The following is a description of a gene set: Human Gene Set: HP_ABNORMAL_RENAL_PHYSIOLOGY species: Homo sapiens An abnormal functionality of the kidney. Abnormal renal physiology, and this is the list of marker genes: TRMT5, BRCA2, AP1S3, COL4A5, POU6F2, PHKB, SMC1A, SCNN1A, NDUFAF8 (NCBI Gene Id 284184), APC2, NUBPL, FN1, REN, HLA-DPB1, ADA, MYH11, VPS33A, DNASE1, IL23R, SLC17A5, BICC1, TBC1D8B, ABCC6, UMPS, HPS1, ETFDH, RRAGD (NCBI Gene Id 58528), DNMT3A, CR2, SLC22A12, NUP85, SMC3, SDHAF2, KLF11, IL36RN, NDUFB3, PBX1, TRIP13, HMBS, TCF4, HPRT1, EHHADH, TTC8, OCRL, OCLN, NUP160, CFHR3, HGD, GLIS2, OSGEP, CLDN10, APOE, TBX18, SALL1, CFAP418, SDCCAG8, FCGR2A (NCBI Gene Id 90764), TNFAIP3 (TNF alpha induced protein 3), ACTN4, BBIP1, IFNGR1 (interferon gamma receptor 1), CTNS, NDUFA6, OFD1, SEMA4D, RAG2, SLC4A4, COL4A6, UQCC2, CISD2, IRF5, COA8, NPHS1, NCF1 (NCBI Gene Id 653844), GSN, DACT1, GP1BA, AQP2, ATP7B, HSD11B2, AMN, ALDH4A1, RPGRIP1L, MYH9, SCAPER, ARL6, FBXL4, TRIM28, FGA, MYO1E, LCAT, MAX, NUP205, SCNN1B, MPV17 (mitochondrial inner membrane protein MPV17, NCBI Gene Id 4358), ERCC4, IFT27, NUP133, MYD88, SLC5A2, BLK, TGM1, NDUFS8, KCTD1, TBX1, FAM20A, PXK, CPT1A, FH, PAX4, NEK8, NDUFS7, SIX5, KIRREL1, KMT2D, FANCA, RNU7-1, SPTBN1, IL17F, GTF2IRD1, STOX1, ATP1A1, IL17RC, FUZ, AGT, LTBP1, EBF3, ANKS6 (ankyrin repeat and sterile alpha motif domain containing 6), MT-CO3, PML, B2M, UBE2T, RET, CD109, ELP1, KLRC4, FANCB, ETFA, ZNF592, SPRY2, ALG9, NDUFAF6, KIF1B, ITGA2, GP1BB, CD2AP, SDHB, IFT56, FIG4, APRT, BRCA1, P4HA2, BBS10, MYO5B (NCBI Gene Id 4645), NADK2, CRB2, PKD1, NDUFB11, MT-ND4, IGHG1, MCFD2, RMRP, IFIH1, CEP290, RMND1, SLC2A9, APOA1, VANGL1, MT-ND6, CLEC7A, MME, ROBO1, PLVAP, IL6, ARHGDIA, XDH, DSTYK, SON, TTR, MT-TL1, CLIP2, DNAJB11, TMEM138, ELN, NSD1, C3, TRAF3IP1, TLR7, ALDH18A1, CC2D2A, TMEM231, VAMP7 (vesicle associated membrane protein 7), AVPR2, CYP24A1, CASP10, CHD7, NR5A1, MT-ND1, APPL1, PDSS2, LIMK1, MAGED2, STS, MMUT, LAMB2, NTRK1, SRY, GPR35, AMMECR1, PRTN3, GATA3, INVS, SLX4, C4A, MTRR, WDR19, JAZF1, CAV1, F2, RFWD3, SARS2, CFB, SCARB2, MYCN, ALG5, ZFPM2, JAK1, G6PC1, NLRP3, EYA1, TPRKB, PAX2, ACE, IFT74, SOX9, NDUFA1, LAGE3, ABCA12, AGGF1, CD46, RASA1, FLT1, TRIM8, OBSCN, SLC25A20, NPHS2, TRIM32, BBS4, DYNC2I1, XYLT1, F5, SHPK, SLC7A7, TCN2, MYOCD, ATP6V0A4, WAS, MOCOS, DLST, FOXP3, LRP2, UBE2L3, HPSE2, CHRNA3, FANCE, DHDDS, XIAP, CLCN5, GON7, HLA-DRB1, PRF1 (NCBI Gene Id 5551), ITGAM (NCBI Gene Id 3684), COQ2, KIAA0753, BBS5, SDR9C7, HMOX1, IFT43, SPP1, IL12A-AS1, SAT1 (spermidine/spermine N1-acetyltransferase 1), NDUFV1, HLA-B (NCBI Gene Id 730410), PFKM, FKBP6, IFNG, DCDC2, DCLRE1C, FANCM, WFS1, FANCF, NDUFAF5, ITGA3, FXYD2, IRAK1, TSC1, KARS1, KCNJ5, SDHC, SLC26A1, KCNJ11, YWHAE, EHMT1, ITGB3, TMEM216, MARS1, NIPAL4, STAT5B (NCBI Gene Id 6777), SLC41A1, PEX7, MIF, DNAJC30, CNNM2, FANCI, IQCB1, PKHD1, LPIN2, SLC34A3, IL10, NOTCH2, BBS1, COQ8B, ETFB, NOS1AP, CEP19, ERAP1, TAF6, CCN2, NUMA1, F8, ASL (NCBI Gene Id 435), ALDOB, MT-ND3, FOXI1, LACC1, SLC5A1, COL7A1, MAP3K1, NDUFA11, PHEX (NCBI Gene Id 5251), IL2RG, IL17RA, PIGA, TBL1XR1, LDHA, CCR1, VPS33B, WDR35, SMARCAL1, GALNT3, BNC2, MT-TS2, ZNFX1, MT-TQ, NOD2, NUP107, NDUFB10, TLR4, FBLN5, FAS, SLC3A1, LMX1B, C4B, UBAC2, KCNJ1, GAPVD1, ALMS1, PRPS1, KCNJ10, ACBD6, DYNC2LI1, NEUROD1, ABCC8, NDUFAF1, CFHR5, MT-TH, LHX1, MT-ND5, YRDC, METTL27, BUD23, CEP164, MPI, SERPINA1, PLCE1, PNPLA6, MED12, CHST14, MT-ND2, NPHP4, STX3, FCGR2B, SDHA, MAPKBP1, NDUFS1 (NADH:ubiquinone oxidoreductase core subunit S1), CPT2, MT-CO1, WIPF1, HOGA1 (NCBI Gene Id 112817), IFT122, PRKAR1A, CFHR1, RARA, CHRM3, CDK4, LMNB2, GTF2IRD2, WWOX, TRPC6, HNF4A, COG1, IVD, DMP1, TMEM165, MLXIPL, PALB2, ERCC8, PRDX1, MST1, NDUFS6 (NADH:ubiquinone oxidoreductase subunit S6), TMEM67 (transmembrane protein 67), CSPP1, ENPP1, ACP5, PIK3CA, DGKE, FASLG (Fas ligand), CA2, REST, STAT3, INF2, ACSL4, JAG1, CLCNKA, ETS1, RAD51, GATM, STX11, PRKCD, MECP2, TMEM126B, RFC2, SNAP29, CEL, HNF1A, BRD4, PMM2, GATA4, LRIG2, COL4A4, IL12A, EIF2AK3, SIX1, NOP10, FOXRED1, CFH, KDM6A (lysine demethylase 6A), RAG1, YAP1, HNRNPK, MKS1, EPAS1, FAH, NDUFAF3, UNC13D, WDR73, GP9, TNIP1, PAFAH1B1, HIC1, CAD, NDUFS2, EMP2, COL3A1, JAK2, PHYH, TBL2, CCNQ, COQ6 (coenzyme Q6, monooxygenase), CYBC1 (cytochrome b-245 chaperone 1), SLC26A4, CD81, ZAP70 (NCBI Gene Id 7535), CLDN16, PYGM, STIM1, COL4A1, VIPAS39 (NCBI Gene Id 63894), PLG, AVIL, F9, AHI1, COPA, TNFSF4, CD151, CASR, CTLA4, INS, PHKG2, SLC4A1, NPHP1, NR0B1, SCLT1, NIPBL, PC, IL7R, VPS37D, PHKA2, BBS2, TREX1, GCK, WDR4, CALR, SLC25A11 (NCBI Gene Id 8402), MEFV, DHX37, SLC2A2, KANK2, SOX18, BBS12, KIAA0586, ITGB4, TIMMDC1, PKDCC, DPH1, BRIP1, LZTFL1, SLC12A3, ALDOA, FCGR3B, LIPN, ANKFY1, BTNL2, GTF2I, MDH2 (NCBI Gene Id 4191), MUC1, MT-TW (NCBI Gene Id 4578), IRF2BP2, MT-TT, SLC30A9, SLC37A4, CCND1, STX1A, MAD2L2, NABP1, PGM3, SLC35A2, NUP93, NDUFS3, SLC34A2, CHD4, HNF1B, LIG4, TTC21B, TBK1, CLPB, TSC2, ADA2, KIAA0319L, EFEMP2, NF1, YY1AP1, STXBP2, ZNF699, INPP5E, F10, SURF1, GCM2, CACNA1S, NFS1, MKKS, SCNN1G, BCS1L, ATP6V1B1, COL4A3, STAT1, ITGA6, TAPBP, CEP120, EIF4H, LARS2, AP2S1, ANLN, DZIP1L, CUBN, PPOX, NEXMIF, GANAB, C1GALT1C1, PEX19, NDUFS4, TMEM270, HLA-DPA1, CCR6, KCNJ2, FCGR2C, SLC34A1, SOCS1, PDCD1, VAC14, GNAS, MAGI2, BCOR (NCBI Gene Id 57686), SLC7A9, ZMPSTE24, COL6A1, PGAM2, SAA1, RRM2B, RYR1, BBS9, DYNC2H1, NDUFAF2, HRAS, DYNC2I2, XRCC2, MEN1, PRODH, GBA1, RAD21, GCDH, BBS7, FAN1, CLDN19, LPIN1, SREBF1, NUP37, DIS3L2, CLCNKB, LYZ, XPNPEP3, CEP83, TMEM260 (transmembrane protein 260), BAZ1B, RAD51C, AGTR1, NDUFAF4, TRAF3IP2, SGPL1, CFI, PAX6 (NCBI Gene Id 5080), H19, GPC3, MT-TF, CDC73, HBB, ITPR3, FANCD2, BSND, NPHP3, ARPC5, APOL1, ASPRV1, ERCC6, COG6, DOCK11, VHL, SLC4A2, ZMYM3, ALOX12B, STAT4, SULT2B1 (NCBI Gene Id 6820), MMACHC (NCBI Gene Id 25974), MAFB, WDPCP, TAOK1, DNASE1L3, HOXA13, ZBTB16, MT-TN, DNASE2, SRCAP, PTPRO, ADAMTS13, FANCG, GLA, CYP4F22, CORIN, ZNF423, HMGA2, BANK1, SH2B1, IFT140, THBD, MMP1, IFT172, MT-CO2, SEC61A1, NDUFB9, KYNU, SERPINF2, ALG1, CPOX, FANCL, ALOXE3, IFT80, WT1, PTPN22, UMOD, FANCC, PUS3, NDUFV2, DKC1, SDHD, AGXT, SLC12A1, ITGA2B, LMAN1, C1QA, KL, STAT2, TMEM237, NPM1, GRHPR, C1QBP, DAAM2, FIP1L1, PGK1, CYB561, TMEM127, LAMA5, TP53RK, PKD2, PDX1, XYLT2, EPG5, IKZF1, ARHGAP24, POLRMT (NCBI Gene Id 5442), KCNE5, MDM2, HDAC8, MT-ATP8, HELLPAR